The following is a description of a gene set: The chemical reactions and pathways resulting in the formation of pyrimidine ribonucleoside triphosphate, a compound consisting of a pyrimidine base linked to a ribose sugar esterified with triphosphate on the sugar. Mouse Gene Set: GOBP_PYRIMIDINE_RIBONUCLEOSIDE_TRIPHOSPHATE_BIOSYNTHETIC_PROCESS species: Mus musculus, and this is the list of marker genes: Uck1, Nme3, Ctps2, Uck2, Nme7, Nme2, Cad, Nme1, Nme6, Nme5, Nme4 (NCBI Gene Id 75413), Ctps1